The following is a description of a gene set: Genes down-regulated in comparison of lineage negative versus erythroblasts. Each fraction of mouse hematopoietic cells was purified by cell sorting from bone marrow of 8-week-old C57BL/6 mice, and its gene expression was analyzed. Human Gene Set: GSE27786_LIN_NEG_VS_ERYTHROBLAST_DN from publication Konuma T, Nakamura S, Miyagi S, Negishi M, Chiba T, Oguro H, Yuan J, Mochizuki-Kashio M, Ichikawa H, Miyoshi H, Vidal M, Iwama A (PMID 21540074) species: Homo sapiens, and this is the list of marker genes: MFHAS1, ABCB6, MARCHF3, SLC22A23, SEZ6L, TRIOBP, MEF2B, NBR1, HRG, C4orf46, CLRN3, ANKLE1, HS6ST1, ALLC, TM2D1, FAM170B, PDX1, PPP1R15B, CPEB4, USP37, CUL9, LIN9, GPR87, AMHR2, CDC42BPB, GULP1, DAAM1, KNTC1, MAMLD1, LAMA2, H2AX, USP32, GRIN1, DHRSX, IBA57, WIPI1, USP29, HDAC6, TNFAIP6, OC90, NKX2-8, LYSMD3, GRINA (glutamate ionotropic receptor NMDA type subunit associated protein 1), TMEM169, CTSF, PCYT1A, TLCD1, CCNA2, MBD2, KRT36, GRIK5, SLC16A6, HOXC6, FANCD2, SYNPO2, ST3GAL4, LHX5, KCTD9 (potassium channel tetramerization domain containing 9), WNT3A, RIBC2, UPP2, TRIM69, MFSD2A, EGR3, MAP3K1, TMEM132D, RAD54L, ARL4A, USP18, SPATA17 (NCBI Gene Id 128153), KNL1, LRRC38 (leucine rich repeat containing 38), PHKG2, FTMT, PIGQ, PITPNM1, TBC1D9, FBXO34, PTCHD1, RIPK4, SHF, DUOX1, REP15, ZSWIM8, CYP4B1, ZNF473, CCDC85A (coiled-coil domain containing 85A), PLA1A, PLCD1, PON2, CARHSP1, PI4K2B, KRTAP3-1, APOL6, E2F8, LRCH4, ALPI, MSR1, SNTG1, BCORL1, KRT26, RAD51C (NCBI Gene Id 5889), KRT8, UBXN11, RPRD1B, DIAPH3, PANX3, SYNE2, ELF5, ADCY5, OOEP, ZSWIM2, SBSPON, SMR3A, LIPN, DNAAF1, NECTIN3, PSMD9, OARD1, SLCO1A2, TRIM23, GID8, TIMP4, MRLN, HAUS8, VPS13D, TNS2, CDK1, RPAIN, CCN3, MIIP, MROH2B, CLIC6, PKD2L2, PAQR3, CEP76, GSTA5, TNFRSF11B, HAPSTR1, NFASC, MFAP4, IFITM5, PRIM2 (DNA primase subunit 2), TTC16, SLC26A3, NDC80, EPN3, RNF39, DOC2B (double C2 domain beta), APOBEC2 (apolipoprotein B mRNA editing enzyme catalytic subunit 2), KIZ, B3GNT3, MACIR, RHD, IRAK2, UBE2S, PDZK1IP1, VSIR, FBLN1, CALHM5, CNTN4, SLC22A18, PRKCG, RCVRN, CDC6, CHAD, EPHB2 (EPH receptor B2), BLVRB, ACBD4, FADS1, ADORA1, ANO3, RHBDL3, BTBD8, C4BPB, SPAG5, CARS1, RBMXL2, TMEM59L, ELF2, KRTAP4-11, PML, PRKAA2, GABRB1, ST3GAL2, ART5, DCLRE1C, RNF19A, SLC49A4, MMRN2, RAC3, PRC1, FEZF1, SLC25A42, DCAF12, ADORA3, VCAN, PCNT, XK, OSBPL10